The following is a description of a gene set: from publication Chen Y, Wang X (PMID 31504780) Genes predicted to be targets of miRBase v22 microRNA mmu_miR_6987_3p in miRDB v6.0 with MirTarget v4 prediction scores > 80 (high confidence targets). studied in species Mus musculus Mouse Gene Set: MIR_6987_3P, and this is the list of marker genes: Pcdh9, Satb2, Npas3, Cdr2l, Fut9, Slc30a7, Sinhcaf, Huwe1, Camkk2, Ackr2, Hnrnph3, Slc35d3, Irs1, Prkar2b, Cdh13, Pogk (pogo transposable element with KRAB domain), Tle1, Tyrp1, Hspa9, Arhgap36, Sema6d, Notch3, Prlr, Bag5, Svopl, Unc79, Krtap6-2, Cadm2, Galnt1, 9030624G23Rik, Lamc2, Abhd10, Mier3, Gas2, Fzd2, Tead4, Hnrnpu, Rp2, Rragc, Hipk1, Eif2a, Oscp1, Cfap43, Myef2, Ugcg, Vdac1, Aplp2